Given this list of marker genes Adprs, Macrod2, Adprh, Macrod1, Oard1, Adprhl1, here is a description of the gene set: species: Mus musculus The process of removing one or more ADP-ribose residues from a protein. Mouse Gene Set: GOBP_PROTEIN_DE_ADP_RIBOSYLATION